Given this list of marker genes TUBB6, CHD9, MLPH (melanophilin), NRN1, ANP32E, CTSB, HNRNPA0, GIT2, SCN8A, KPNB1, ITGB1, IRAG1-AS1, NCOR1 (NCBI Gene Id 9611), KASH5, MT-ND5, ZNF470, FAM242E, EIF1, NYX, PCYT1A (phosphate cytidylyltransferase 1A, choline), HENMT1, FAN1, SIGLEC1, FTH1P5, PTMA, RASSF8, DHX16, ERCC2, HNRNPA1, GGTLC1, FAU, FNDC5, here is a description of the gene set: from publication Liu BH, Goh CH, Ooi LL, Hui KM (PMID 18332864) Low abundance transcripts specific for breast cancer. species: Homo sapiens Human Gene Set: LIU_BREAST_CANCER Most human cancers are characterized by genetic aberrations accompanied by altered expression and function of numerous genes. Applying genome-wide, microarray gene expression analysis to identify deregulated genes in different tumour types can provide potential gene candidates as diagnostic and prognostic tools and promising targets for drug development. However, the detection of deregulated genes with low levels of expression remains a major challenge. In this study, we have designed a strategy, termed modified suppression subtractive hybridization (mSSH), to identify genes encoding rare transcripts. The strategy entails incorporating the T(7)-promoter sequence at the 5' end of the noncoding cDNA strand during first strand cDNA synthesis to generate unidirectional antisense RNA from the resultant cDNA following conventional SSH. These transcripts are subsequently analysed by Affymetrix oligonucleotide gene arrays. Here, we have used five hepatocellular carcinoma (HCC), five breast carcinoma and four nasopharyngeal carcinoma (NPC) biopsies separately as testers and their corresponding normal biopsies as drivers to enrich for low abundance tumour type-specific transcripts. The total detectable number of probe sets following mSSH was reduced almost 10-fold in comparison to those detected for the same resected tumour tissues without undergoing subtraction, thus yielding a subtraction efficacy of over 90%. Using this experimental approach, we have identified 48 HCC-specific, 45 breast carcinoma-specific, and 83 NPC-specific genes. In addition, genes were upregulated in all the three cancer types. When compared to gene-profiling data obtained without mSSH, the majority of these identified transcripts were of low abundance in the original cancer tissues. mSSH can therefore serve as a comprehensive molecular strategy for pursuing functional genomic studies of human cancers.